The following is a description of a gene set: species: Mus musculus Any process that modulates the rate, frequency or extent of mast cell differentiation, the process in which a relatively unspecialized myeloid precursor cell acquires the specialized features of a mast cell. A mast cell is a cell that is found in almost all tissues containing numerous basophilic granules and capable of releasing large amounts of histamine and heparin upon activation. Mouse Gene Set: GOBP_REGULATION_OF_MAST_CELL_DIFFERENTIATION, and this is the list of marker genes: Pla2g3, Itgam, Stat5a, Zfpm1, Tal1 (NCBI Gene Id 21349)